The following is a description of a gene set: Formation of definitive endoderm Human Gene Set: REACTOME_FORMATION_OF_DEFINITIVE_ENDODERM species: Homo sapiens, and this is the list of marker genes: SMAD3, SOX17, TBXT, SMAD4, LINC00261, CDH1, MIXL1, GATA4, TCF7L2, GSC, FOXA2, CTNNB1, GATA6-AS1, GATA6, SMAD2, CXCR4, EOMES (NCBI Gene Id 8320)